The following is a description of a gene set: Vitamin D-sensitive calcium signaling in depression Human Gene Set: WP_VITAMIN_DSENSITIVE_CALCIUM_SIGNALING_IN_DEPRESSION studied in species Homo sapiens, and this is the list of marker genes: ITPR1, SLC8A1, GRIN2D, ITPR3, TPH2 (tryptophan hydroxylase 2), GRIN2B, GCLC, GRM5, ATP2B3 (NCBI Gene Id 492), TPH1, CHRM1, KDM1A, KCNQ3, CACNA1C, CALB1, BCL2, KCNQ2, ATP2B1, GRIN2C, ATP2B4, GRIN1, GSR, GRIN2A, VDR, CYP27A1, ATP2B2, GGT1, KDM6B, KDM3A, KDM1B, PVALB, CYP27B1, RXRA, ITPR2, G6PD, NFE2L2